The following is a description of a gene set: from publication Zhang L, Long W, Xu W, Chen X, Zhao X, Wu B (PMID 35669188) species: Mus musculus Mouse Gene Set: ZHANG_UTERUS_C11_SMOOTH_MUSCLE_CELL Table S2: Representative genes of each cell cluster, and this is the list of marker genes: Des, Mylk, Myh11, Hspb1, Csrp1, Mustn1, Cox6c, Myl9, mt-Nd4, Gadd45b, Cpe, mt-Rnr1, mt-Cytb, Cald1 (caldesmon 1), mt-Nd2, Sparcl1, Cox7c, mt-Nd1, Rrad, Acta2, Tpm2, Smtn, Pcp4, Myl6, Rpl38, Tpm1, Actn1, Actg2, Crip2, Flna, Tagln, Cox8a, Rps21, Pdlim3, Cnn1, Tgfb1i1